Given this list of marker genes SIX1, RDH10, ESR1, SPRY1, HOXD13, FGFR2, SOX9, YAP1, TNC, SHH, FGF10, SPRY2 (sprouty RTK signaling antagonist 2), TGFB1, TFAP2C, MED1, FGF1, WNT5A, BMP4, AREG, HNF1B, SIX4, here is a description of the gene set: The growth process in which a branch increases in length from its base to its tip. species: Homo sapiens Human Gene Set: GOBP_BRANCH_ELONGATION_OF_AN_EPITHELIUM